Given this list of marker genes STX16, GATA6 (NCBI Gene Id 2627), MAP2K1, LETM1, H4C5, EYA1 (NCBI Gene Id 2138), HDAC9, ZNF462 (NCBI Gene Id 84452), AGL, BCKDK, CAV1, FAT4, H4C3, SVBP, EEF1A2 (eukaryotic translation elongation factor 1 alpha 2), CEP290, DLK1, BMP2, STAG2, MEG3, HEATR3, GPC4, PIGB, KDR, FGFRL1, FBN1, PIK3CA, MAP3K7, KDM6A, PCLO, RNU4-2, EXTL3, HRAS, IDUA, HK1, SH3BP2, LIFR, IRX5, FBLN5, KLHL7, BCOR, AFF4, TMEM107, CITED2, ASXL1, GPR101, ATP7A, NKX2-6 (NCBI Gene Id 137814), KCNJ2, HSPG2, LARS1, NPHP3, VPS33A, LRP5, TMEM237, MAPK8IP3, UBE2A, KMT2D (lysine methyltransferase 2D), MED12, AUTS2, LTBP1, UBE3B, IER3IP1, CDK5, POLR1B, RAP1B, ALX1, DPYSL5, TFAP2A, TCF4, POLR1C, ACTB, TMEM67, SNX14, SLC29A3, SLC35A2, KIF7, TBL1XR1, H4C9, B9D2, ZFPM2, B9D1, ACTG1, FBXO11, GJA5, STXBP1, GNAS, CLCN3, WDR26, NRAS (NRAS proto-oncogene, GTPase), MAFB, TMEM231, FLNB, IDS, SETD1A, WDR19, TRPM3, JAG1, MAP2K2, MSL3, TCTN3, ZFX, RPGRIP1L, TMEM216, DICER1, DTYMK, H1-4, SALL1, RPGRIP1, KMT2E, BICRA, WNT3, SIX1, MOCS2 (molybdenum cofactor synthesis 2), ARID1B, EIF2AK3, TMEM260, CTBP1, CYP26C1, IFT52, DDX3X, TECPR2, SOX11, CLCF1, COL2A1, LMX1B, PIGQ, ALX3 (NCBI Gene Id 93575), DPM1, FGFR2, DDB1, MID1, ESAM, NOTCH2, CHD7, FLT4, CSPP1, MTHFS, MOCS1, KDM6B, TGDS, HNRNPK (NCBI Gene Id 3190), IFT122, CDC42BPB (CDC42 binding protein kinase beta), CCDC22, WLS, TBX1, SH3PXD2B, WDR35, ANKRD11, EP300, NGLY1, IFT140, VPS35L, NELFA, OCRL, FN1, GDF1, ZNF668, SETD1B, KCNH1, EDNRA, TBCE, GNPTAB, CCDC88A, MITF, KRAS, SLC26A2, FGF3, TFE3, EIF2S3, GLI2, PPP1R15B, CC2D2A, SF3B2, TCTN1 (tectonic family member 1), SLC37A4, SMARCA2, CPLX1, TXNL4A, SYK, PSPH, PPP1CB, RAB23, MYT1L, KMT2B, WBP11, NAA10, PRMT7, PURA, NEK9, TCOF1, SF3B4, MLXIPL, FGFR1, WASHC5, KIF11, SLC4A10, CTNND2, GNAI3, IARS1, PSMC3, LMNA, TUBB4A, AIP, BRAF, SPECC1L, ELMO2, UFC1 (NCBI Gene Id 51506), NSD2, PAX1, SPTBN1, SEMA3E (NCBI Gene Id 9723), EXT2, WAC, GSC, PIGG, ATP6V0A2, NKX2-5, KIDINS220, EFEMP2, RTL1, DPYD, TBX4, CRELD1, ZPR1, EFTUD2, HNRNPU, ANK1, ATP6V1E1, ZNHIT3, EDN1, NALCN, SIX5, YARS1, FGD1, AEBP1, SNRPN, CREBBP, LRP1, PUF60, POLR1D, SALL4, MED13L, VPS13B, TAFAZZIN, KAT6B (lysine acetyltransferase 6B), XYLT2, RERE, PCNT, TRMT10A, TASP1, PLCB4, SON (NCBI Gene Id 84155), ODC1, GNB2, DACT1, CPE, SHANK3, SIM1, BRF1, GATA4, GPC3, GATA5, LTBP3, TXNDC15, KAT6A, CHN1, PYCR1, PIGS, SC5D, ELN, PIGN, B3GLCT, CRLF1, INTS1, MKS1, RSPO2, FLNA, SEMA5A, TCTN2, here is a description of the gene set: Human Gene Set: HP_ABNORMAL_CHEEK_MORPHOLOGY Abnormal cheek morphology An abnormality of the cheek- one of two bilateral soft tissue facial structures in the region of the face inferior to the eyes and between the nose and the ear. \Buccal\ means relating to the cheek. The cheek is part of the midface studied in species Homo sapiens